The following is a description of a gene set: species: Homo sapiens Here we show that tumor necrosis factor (TNF) induced in human T-regulatory cells (Treg), as compared to conventional T cells (Tcon), a transcription program highly enriched for typical NF-κB target genes, such as: the cytokines LTA and TNF; the TNF-receptor super family members FAS, 4-1BB and OX-40; various anti-apoptotic genes; and other important immune-response genes. As an initial approach to examine the cellular program induced by TNF in Tregs versus Tcon cells, we employed microarray gene expression analysis at 2 and 24 hrs following TNF treatment. Human Gene Set: GSE18893_CTRL_VS_TNF_TREATED_TCONV_24H_UP from publication Nagar M, Jacob-Hirsch J, Vernitsky H, Berkun Y, Ben-Horin S, Amariglio N, Bank I, Kloog Y, Rechavi G, Goldstein I (PMID 20181891) Genes up-regulated in T conv cells (24h): medium versus TNF., and this is the list of marker genes: THRAP3, TRAIP, PSMA1, ZMAT2, DPP3, NELFB, GOLGA4, PTPN11, SCFD1, AJUBA, TCEAL9, RPAIN, ANTKMT, HRAS, DPP4 (dipeptidyl peptidase 4), TOR1B, SPAG4, ZBTB44, AP4M1, C22orf39, ZC3H7B, MRPL10 (NCBI Gene Id 65004), TRPM7, HMGN3, NPHP1, MC5R, RASSF8, TIMM17B, ZBTB14, JPT1, SLC35B4, SLC25A23, C2orf76, P2RY2, ETFDH, TENT5A, LIX1L, NUDT2 (nudix hydrolase 2), TMEM87A, EIF2B2, NUP214, IRF4, HADHA, ZNF438, TUBE1, BLZF1, ZZZ3, OOSP2, TANGO6, NT5DC3, BEX4 (brain expressed X-linked 4), KIF18A, MYO19, GAREM1, GRPEL2, VPS53, ZNF653, MIS12, ABHD14A, FERRY3, SFT2D3, RRAD, NXF1, IFI30, ZNF318, CDH16, MLLT3, TNPO1, CREB3L2, TRAF3IP1, DENND1A, SELP, ST14, SUPT3H, LSM12, GAS2L3, PARP8, STAU1, FBXO45, BPHL, AGO1, MEX3D, RABGAP1L, PTAR1, DPAGT1, MYL4, DDX28, ARHGAP5, MTFR1, PHETA2, FZD4, NRGN, DNAJA2, ACTR5, VANGL2, FPGS, ATMIN, RPL18A, SPN, ANKDD1B, GPATCH1, HEBP1, SEPTIN2, CSTB, BUB1B, SRBD1 (NCBI Gene Id 55133), MRPS16, CHCHD10, CNTRL, TRAPPC2B, JADE1, G2E3, NNT, EIF3F, DIAPH3, TTC33, CHST14, TJP2, APIP, RBAK, TACC1, ZFYVE19, ASB13, GP5, ACLY, GPATCH4, TIA1, ANAPC16, SCAF4, NUMA1, ZFTA, B3GALT6, SEC24C, CPSF2, PIGO, DYNC2I1, MYL10, GABPB2, PRICKLE1, HNRNPLL, LETM1, SMIM30, ELMOD3, TTC32, GLRX3, ATG10, SETDB2, PRG3, PWWP2A, SLC22A5, CCDC120, TMX1, RPL31, API5, METTL15, ANAPC10, WDR24, DICER1, TANC2, CEBPZ, DHX9, GPD1L, LSM7, RPTOR, TGIF1, NPM3, CISD1, LUZP1, ARMCX2, KAT7, CEP152, STAU2, SLC13A2, AFG2A, FRZB, SETD6, SNRNP27, DHX15, CALHM6, EIF3K, BLTP2, MARVELD2, YRDC, RRBP1, RTEL1, ENDOU, TRAPPC6A, KIFBP, MORF4L1, ZNF227, PPIA, ANAPC4, SPPL2B, CCDC59, SYPL1, NSA2, CRYL1, CDC27, UBA1 (ubiquitin like modifier activating enzyme 1), NAPEPLD